The following is a description of a gene set: from publication Boylan KL, Gosse MA, Staggs SE, Janz S, Grindle S, Kansas GS, Van Ness BG (PMID 17483317) Genes down-regulated in group C of tumors arising from overexpression of BCL2L1 and MYC in plasma cells. Multiple myeloma is an incurable plasma cell malignancy for which existing animal models are limited. We have previously shown that the targeted expression of the transgenes c-Myc and Bcl-X(L) in murine plasma cells produces malignancy that displays features of human myeloma, such as localization of tumor cells to the bone marrow and lytic bone lesions. We have isolated and characterized in vitro cultures and adoptive transfers of tumors from Bcl-xl/Myc transgenic mice. Tumors have a plasmablastic morphology and variable expression of CD138, CD45, CD38, and CD19. Spectral karyotyping analysis of metaphase chromosomes from primary tumor cell cultures shows that the Bcl-xl/Myc tumors contain a variety of chromosomal abnormalities, including trisomies, translocations, and deletions. The most frequently aberrant chromosomes are 12 and 16. Three sites for recurring translocations were also identified on chromosomes 4D, 12F, and 16C. Gene expression profiling was used to identify differences in gene expression between tumor cells and normal plasma cells (NPC) and to cluster the tumors into two groups (tumor groups C and D), with distinct gene expression profiles. Four hundred and ninety-five genes were significantly different between both tumor groups and NPCs, whereas genes were uniquely different from NPCs in tumor group C and genes were uniquely different from NPCs in tumor group D. Similar to human myeloma, the cyclin D genes are differentially dysregulated in the mouse tumor groups. These data suggest the Bcl-xl/Myc tumors are similar to a subset of plasmablastic human myelomas and provide insight into the specific genes and pathways underlying the human disease. Human Gene Set: BOYLAN_MULTIPLE_MYELOMA_C_DN studied in species Mus musculus, and this is the list of marker genes: SLC30A1 (solute carrier family 30 member 1), TNFRSF21, FZD6, ZC2HC1A, ZSWIM6, TSC22D1, EGLN3, SFMBT2, TANC1, IFT43, SMR3A, AK7, SPP1, NRIP1, KLF6, BCL11B, APOE, RAB20, RGS1, AIG1, BICD1, SERPINB1, CKB, EID2, CYSTM1, IRS2, C3orf33, ABCB1, PLOD2, KIF13A, MAGEH1, B4GALT6, SOAT1, DOCK5, MYOF, SAT1, XIST, ZBTB10, CERS6, LINC-PINT, ENAH, RNF43, KCNN4, BPIFA2, VOPP1, ATXN1, RAB30, RNF125, G6PC3, JUN, KCNQ1OT1, MAP9, CTSV, KLF7, LAPTM4B, TMEM191C, FAM234A, NFIC